The following is a description of a gene set: electronically inferred by orthology from the curated human pathway part of: Neuronal System studied in species Mus musculus This event has been computationally inferred from an event that has been demonstrated in another species.<p>The inference is based on the homology mapping from PANTHER. Briefly, reactions for which all involved PhysicalEntities (in input, output and catalyst) have a mapped orthologue/paralogue (for complexes at least 75% of components must have a mapping) are inferred to the other species. Reactome Pathway: Potassium Channels, and this is the list of marker genes: Kcnj11, Kcnj12, Hcn2, Gng10, Kcnk4, Kcnj8, Kcnc3, Gngt2, Kcnmb1, Gnb5, Kcns1, Gng11 (guanine nucleotide binding protein (G protein), gamma 11), Kcng3, Kcnj3, Kcnk3, Kcna6, Kcnk18, Kcna10, Kcnab2, Kcnh8, Kcnh6, Gnb2, Gng7, Kcnv1, Kcnj14, Kcnn3, Kcnn1, Kcna2, Gng3, Gng4, Kcnh5, Kcng4, Gnb3, Kcnj5, Kcng2, Kcnq4, Kcnc4, Gng8, Kcnh1, Kcnj1, Kcnab1, Gngt1, Kcnb2, Gabbr1, Kcnb1, Kcnj2, Kcnv2, Kcnf1, Hcn3, Kcnk16, Kcnk6, Hcn4, Kcnn4, Kcnj10, Gng5, Kcnh2